Given this list of marker genes CLTC (clathrin heavy chain), CSNK1G3, KIT, DHX40, WDR37, SGPL1, CDC23, CD14, NDUFA2, CHPT1, PCDHA9, TENM1, RNASE4, RASSF2, PECAM1, CLDN6, IARS2, CMPK1, BIN1, EIF4B, INPP5A, NDUFC2, ZNF140, DENND1A, MPP1, RHOA, ZC3H14, HEXB, MSRB2, TAGLN2, MSANTD2, SLC35A1, DBP, ZDHHC11, DPT, KLF7, P4HTM, MTRF1, PCYOX1L, S100A6, AVL9 (AVL9 cell migration associated), FPR3, PIH1D1, PANK3, BIN2, RTL8C, TGOLN2, UQCRC2, TBL2, CUTA, DDOST, LINC00342, SACS (NCBI Gene Id 26278), UTP18, GAL3ST4, YIF1A, KLRB1, DDX41, PHKG2, HIGD1B, DDHD2, UBA52, PKD2, SIL1, PKP4, RCBTB2, XPO7, BPNT2, BNIP3, CALM2, ZBTB18, COIL, SLC25A46, ATP6V0D1, FAM8A1, CDC34, EIF2AK1, APOLD1, VAMP1, MARCHF1, KLHL24, FBLN1, CDV3 (NCBI Gene Id 55573), AMMECR1, POLR1E, APPBP2, FOS, CANX, CDIPT, IGF2-AS, MACROH2A2, ZNF34, PTGS1, ZNF133, SPTBN1, RNF139, LXN, MBNL2, PABPC3, GASK1B, CEBPA, TEX2, BLVRA, CD36, ANG, HACD2, PPARG, LRRC8D, ACTL6A, GLT8D1, ZNF124, NARS1, RMND5A, DPY19L2P2, SLA, ZMPSTE24, MTMR4, RDH11, VPS13B, ZNF137P, NEK9, GET1, HSPA14, USP10, PSAP, TREM2, ZBTB11, FABP4, EIF2D, HK3, PDIA3, PPM1D, BLVRB, CSRP1, MACROH2A1, TSC22D3, RPL21, AKR1A1, KXD1, PI4K2A, BRCC3, SIN3B, RPS6KB1, SPTLC1, CLIC1, FOCAD, ABHD11, VAMP8, GLG1, UBR5, VPS37A, PPCDC, CEP15, HIPK2, SRSF1, GSN, LSM14A, ANKRD49, RB1CC1, NACA, COMMD10, GAA, GIT2, PGD, ATP1A1, DSTN, CEP63, NCOA4, SH2D1A, TRAM2, FCN1, INPP4A, ARID1A, NACC2, EEF1B2, RPL17, LRRC42 (NCBI Gene Id 115353), PLBD1, PCYOX1, PSME4, FIG4, MZT2B, KDELR2, PRR13, NEK7, IQGAP1, ZFAND3, MACF1, CLEC5A, YBX1, HP1BP3, SUMO3, ORC5, ADAP2, IDH2, TPST2, SKIC3, HLA-DMA, PLA2G15, here is a description of the gene set: Genes up-regulated in comparison of unstimulated peripheral blood mononuclear cells (PBMC) cultured for 12 h versus PBMC cultured for 12 h with YF17D vaccine. species: Homo sapiens from publication Querec TD, Akondy RS, Lee EK, Cao W, Nakaya HI, Teuwen D, Pirani A, Gernert K, Deng J, Marzolf B, Kennedy K, Wu H, Bennouna S, Oluoch H, Miller J, Vencio RZ, Mulligan M, Aderem A, Ahmed R, Pulendran B (PMID 19029902) Human Gene Set: GSE13484_12H_UNSTIM_VS_YF17D_VACCINE_STIM_PBMC_UP The immune responses generated by YF-17D by profiling genes in PBMCs from 2 donors cultured with YF-17D vaccine were accessed after 3 and 12 hours.